The following is a description of a gene set: Intrinsic Pathway for Apoptosis Mouse Gene Set: REACTOME_INTRINSIC_PATHWAY_FOR_APOPTOSIS species: Mus musculus, and this is the list of marker genes: Dynll1, Casp9, Ppp3cc, Ppp3r1, Gm10053, Ywhah, Casp3, Gsdmd, Bcl2l11, Bid, Bmf, Mapk3, Bad, Ywhae, Mapk8, Bcl2l1, Ywhag, Gsdme, Ywhaq, Xiap, Bak1, Bcl2, Nmt1, Dynll2, Mapk1, Diablo, Gzmb, Sfn, Aven, Cycs, Pmaip1, Apip, Bax, Casp7, Septin4, Apaf1, Ywhab, Casp8, Ywhaz